Given this list of marker genes ATP6V0A2, ATP6V1E1, APC2, NIPA1, NIPA2, RELN, PAFAH1B1, TBC1D24, TUBG1 (tubulin gamma 1), CPLX1, ATP6V1A, here is a description of the gene set: studied in species Homo sapiens Human Gene Set: HP_THICK_CEREBRAL_CORTEX Thick cerebral cortex